Given this list of marker genes Tmx4, Myot, Zbtb41, Ubxn2a, Jade3, Zfp953, Gclc, Tm6sf1, Kdm1a, Ulk1, Fhip1a, Hecw1 (NCBI Gene Id 94253), L3mbtl3, Cps1, Golph3, Mex3c, Mxd1, Tbc1d23, Gab1, Zeb2, Rnf146, Slain1, Dennd6a, Ttn, Esrrg, Cpne8, Kansl1l, Cplx1, Hipk1, Prrg1, Zfp458, Ppp4r3a, Zfp619, Jmy, Zfpm2, Cp, Prc1, Rab14, Tfg, Tob1, Lrrtm2, Bcl11a, Dhx40, Slc35e2, Hnrnpa2b1, here is a description of the gene set: Genes predicted to be targets of miRBase v22 microRNA mmu_miR_503_3p in miRDB v6.0 with MirTarget v4 prediction scores > 80 (high confidence targets). Mouse Gene Set: MIR_503_3P from publication Chen Y, Wang X (PMID 31504780) studied in species Mus musculus